The following is a description of a gene set: Human Gene Set: GSE2770_IL12_AND_TGFB_ACT_VS_ACT_CD4_TCELL_6H_UP Genes up-regulated in CD4 T cells activated by anti-CD3 and anti-CD28: TGFB1 and IL-12 (6h) versus untreated (6h). Th1 and Th2 cells arise from a common precursor cell in response to triggering through the TCR and cytokine receptors for IL-12 or IL-4. This leads to activation of complex signaling pathways, which are not known in detail. Disturbances in the balance between type 1 and type 2 responses can lead to certain immune-mediated diseases. Thus, it is important to understand how Th1 and Th2 cells are generated. To clarify the mechanisms as to how IL-12 and IL-4 induce Th1 and Th2 differentiation and how TGF-beta can inhibit this process, we have used oligonucleotide arrays to examine the early polarization of Th1 and Th2 cells in the presence and absence of TGF-beta after 0, 2, 6 and 48 hours of polarization. from publication Lund R, Aittokallio T, Nevalainen O, Lahesmaa R (PMID 14607935) species: Homo sapiens, and this is the list of marker genes: TRAM2, ZFP36L2, MTARC2, ADA2, ZNF334, ID3, TCEAL1, PLCG2, LEPROTL1, H2AC25, SLC35E2B, KCTD7, AMPD3, VASH1, KDELR3, RPS20, ATP8A2, MAP3K6, NDE1 (NCBI Gene Id 95348), SIDT2, WHRN, PDLIM1, GALNT12, AOAH, DPEP2, ZBTB40, FGD6, CUX2, BTN3A2, ELAPOR1, CXCR4, DHRS3, RAMP1, GSE1, INPP5D, ITM2C, MMRN1, CDKN1B, CD44, LBH, KLKB1, MAN1C1, TMSB4Y, GABPB1-IT1, FAHD2A, GNG7, ALAD, EVL, TRAC, FLNB, ZNF589, DYNC2H1, CLCA4, TMEM14A, MLC1 (modulator of VRAC current 1), BSCL2, TMT1A, COLGALT2, GRAMD1C, APBA2, DHRS1, DEPTOR, CTDSP2, EPHB6, SPON2, IFNA8, QSER1, GRM6, BBS9, SLC16A5, PLCB2, ZNF862, KCNE4, PYHIN1, RPL11, PRCP, PIK3IP1 (phosphoinositide-3-kinase interacting protein 1), DCAF8, NDRG3, EPHX2, CXCR2, LDLRAP1, ACP6, DTNB, ZFYVE26, CYTH4, LY9, RNASET2, EGOT, TCF7, C2orf68, BTF3P12, SFXN3, ADAMTS20, RNASEL, TSPYL4, GALNT11, HLA-F-AS1, TARP, OPHN1, LPCAT4, PRM2, OXA1L, EEIG1, HMCES, C14orf132, SFRP4, SIRT4, MCTP1, PBXIP1 (PBX homeobox interacting protein 1), RPS17P5, MEGF8, UST, ABHD4, TCTN2, FOXO3, TBC1D8, ZNF343, INSL5, SPTBN1, POMT1, RGS10, FAM200C, ZNF671, CACNA2D2, RASSF2, SELENOP, PTPRS, WDCP, KNL1, CAV1, NMT2, LRP5L, ZFP30, PECR, NBEA, COL6A3, BTN3A3, CYP2R1, GALNT3, PEX11A, LIME1, TRDV2, ADAM30, DDB2, BBS4, SALL2, HTR1F, BMERB1, TNFAIP3, PPOX, TRAF3IP3, RCAN3, PCNX2, GNB5, NLRP1, PHC1, SLC24A1, SIGIRR, TSC22D3, NACAD, IL16, CDH12, PRRC2B, SNHG32, PRMT8, LETMD1, AMT, CSNK2A2, ATRNL1, CCDC28B, COG4, ABCD4, TPP1, ITGB7, SMYD3 (NCBI Gene Id 81838, SET and MYND domain containing 3), SPOCK2 (NCBI Gene Id 9806), SIRPG, ZNF506, WNT16, PLXDC1, ANO10, UBASH3A, GLS2, RAB38, CAPN2, SLC1A4, SEPTIN9, SOX12, IL11RA, RIN3, ZNF695, ZMYM3, SCAPER, AVIL, LEP, CHRDL1, MXD3, IFT140 (NCBI Gene Id 9742), KRT86